The following is a description of a gene set: species: Homo sapiens Genes containing one or more binding sites for (ZNF2) in their promoter regions (TSS -1000,+100 bp) as identified by GTRD version 20.06 ChIP-seq harmonization. from publication Yevshin I, Sharipov R, Kolmykov S, Kondrakhin Y, Kolpakov F (PMID 30445619) Human Gene Set: ZNF2_TARGET_GENES, and this is the list of marker genes: MIR3677HG, BCRP2, ELL, ZSWIM8, ASPHD1, SVOP, FYN, CCDC25, EIF4ENIF1, LIN9, JMJD1C, MRPL22, SLC25A16, ZFAS1, TBL3, PSMD14-DT, MRPL54, SLC24A1, BTG1-DT, PLAAT1, CIB4, MRPL42, TXLNB, CLYBL-AS2, SLC39A11, RBM18, BBS4, SRGAP3, LINC01569 (NCBI Gene Id 100507501), GNB2, PRKCSH, FGD4, RIOX1, HDAC2, METTL1, KCTD14, FAM241B, NSL1, GNA13 (G protein subunit alpha 13), CLPTM1, PHF20, VPS16, FTCD, CCDC88C, ZEB2-AS1, STOX1, CELF4, RPL7A, CNPY2-AS1 (NCBI Gene Id 112268098), DDX19B, RAB11FIP3, TOP3B, DENND5B-AS1, KCTD10, MPLKIP, ZNF385A, TRAPPC3, MYL6B-AS1, CZIB-DT, VPS25, METTL25B, ZSCAN31 (zinc finger and SCAN domain containing 31), TLCD3B, SKIC8, MAPK1IP1L, ITFG2-AS1, BRD8, GRIN2A, CMBL, HSPB6, IL10RA, XPOT, STX16, COMMD2, SERBP1, LTA4H, FNTB, ZCCHC24, UBE2V1P4, ADGRG7, URGCP, ERO1B, AARS1, MMS19, NUCKS1, CUL4A, ZNF3, NTF3, DYRK4, FAM114A2, YBX3, AKAP1, NOL8, RAB2A (RAB2A, member RAS oncogene family), RAC1, CCDC194, B4GAT1-DT, RBM41, LINC03047 (long intergenic non-protein coding RNA 3047), CASP9, AP3B2, TUT1, MRPL48, SERPINI1, ERBIN, POC5, TRAFD1, LRRC23, GUSBP11, HDAC5, RAPGEF3, KLHL17, BUD31, ATP5MC1, BCKDK, NDUFC1, TTLL7 (tubulin tyrosine ligase like 7), ZNF217, LINC01902, HCST, PDS5A, DIAPH1, THUMPD1, SHOC2 (SHOC2 leucine rich repeat scaffold protein), PPP2R5C, ETV2, PARK7, PTPRK, POLR2J3, MED23, INTS8, STARD10, PNPLA3, DHX16, ATAD3A, MYL6, TMEM255A, OGDH, EME1, SH2D7, TIAL1, PRPF40B, UMPS, RPS27, CETN3, UBE2I, PDLIM2, CENPT, SLC25A51, COQ3, MTMR9, STX3, ENSG00000255647, MIR194-1, DECR2, HMG20A, MIR3928, IFFO2, NUFIP2, USP35, CNOT6 (CCR4-NOT transcription complex subunit 6), ST6GAL2, BABAM2, TMEM219, ID2-AS1, BNIP1, SCAI, SYT9-AS1, MIR7977, CRKL, ZNF140, GHR, MRPL4, ISCA1, NSD3, ZNF341, LRRC8C, PRKAR1A, NCOA4, TNPO1, TMTC2, STYK1, EIF1AD, RNU2-17P, ZDHHC17, TMCC2, HSD17B4, SNRPD3, HOXB7, ARHGAP22, MRPL13, NUDC, FRMD4B, KRBA1, MAP3K5, ANP32E, CTPS1 (NCBI Gene Id 1503), LEISA1, KAT6B, AAAS, NCBP2, THG1L (NCBI Gene Id 54974), PBX3-DT, CUL2, H4C8, GGCTP1, ZNF260, STAU2, MIR1273C (NCBI Gene Id 100422821), VAV3, P3H3, RPS3, SHPRH, UBE2D4, ENPP1, ZBTB45, INTS1, WASHC2A, NKAPD1, UBE2Q2P1, BORCS8, RNF146, FCHO2-DT, LRFN2, ZMPSTE24, CHIT1, C10orf88, PRPF18, MPHOSPH9 (NCBI Gene Id 64797), BANF1, LETM2, PRCC, VTA1, ARRDC2, PARN, CASP8, TSC1, PEG10, ZNF790-AS1, DTD1, ZNF511, SNORA13, C1QTNF1, GMNN, DHFRP2, FAAP20, BBX, MCM7, NBPF25P, PGBD2 (NCBI Gene Id 267002), GATA3, PSTK, LINC00240, NUFIP1, FGF13, CPVL, TRUB2, DUSP1, ADAP2, MTRFR (NCBI Gene Id 91574), SUGCT, TSPEAR-AS1, SDCBP2, STK17B, SARAF, CORO1A, FCHO2, ROGDI, GFI1B, CITED2, NUDT3, ERBIN-DT, WDR25, CS, ZZEF1, AKT3, TRIP4, KDM8, FAM133GP, ADAT2, MIF, MIR4799, P2RX5, ZNF30, MIR5091 (NCBI Gene Id 100847023), RNF216, SLC33A1, EFHC1, PROX1 (prospero homeobox 1), ZNF623, MLH1, STUM (stum, mechanosensory transduction mediator homolog), RAP1GAP2, ZNF345, THUMPD3, SLC1A3, NECTIN2, C11orf71, RBM22, TBC1D4, DRG2, COX5A, NUBP1, INO80B, FLNA, CHMP7, BTG1, KCTD5, TMEM161B-DT, CRHR1, HOMER2, ARSA, EMX2, VPS45, HDGFL3, SMARCC2, KLHL32, TSC22D1-AS1, SNORD15A, FNDC5, POP4, RPL5, PPP2R2A, IFT56, CDK16, ADD2, SMG7, RYR2, FAM184A, PANK1, MLEC, CACNA1H, FOXJ1, PEX3, EMC3-AS1, NR2F6, AP4M1, IRF6, NCAPH, DENND4A, FAM227B, SPSB3, SHARPIN, PDZD7, APBA3, GATC, PRELID1, IL12B, IFTAP, SIRT4, JADE2, PDCD6P1, BRF2, MKLN1, KANSL2, TMEM128, SOAT1, EIF2B4, MIR100HG, UBTD1, PFKFB3, ANO8, PDZD2, HUS1, KYAT3, FAM193B-DT, MTBP, ITGA5, TMEM14A, NUDT19, ZNF674-AS1, GPR3, PCDHGB5, SPATS2, CCNJL, RBMX, GORASP2, VPS51, GNB5, KIFBP, LINC02960, PCDH1, CCSER1, ZNF284, SMIM26, KCNJ11, HINT3, LINC02236, ZNF860, EIF1, GNPNAT1, KCNK1, PROX1-AS1, CYB5D2, ENPP3 (ectonucleotide pyrophosphatase/phosphodiesterase 3), ROBO3, KCNIP2, AURKAIP1, GLOD4, KMT2D, CNIH3, PCDHB2, ANKRD24, ZNF225-AS1, DNAI1, MRPL39, ZBTB18, HSPB1P2, RAB24, ZNF674, PDXK, RNA5SP160, UROS, IK, SLC4A1AP, C10orf67, RNU5F-1, NFE2L1-DT, FLJ13224, MYOM3, MAN2A2, ZBTB22, TSPAN9, TSC22D4, DDN, RAB11A, PEX10, SRRM1, SMARCD3, TTLL4, GLA, HOMER1, PRKAA1, SSH1 (NCBI Gene Id 54434), H3-3A, RASD2, WNT1, SPINT2, THAP1, GOLGA3, MGRN1, LINGO1, ST7, MYH9, LASP1, AGAP2-AS1, PKNOX1 (NCBI Gene Id 5316), PMPCB, TXNIP, PAPOLA, SYMPK, TSKU, PCDHB3 (NCBI Gene Id 56132), RNY3, MARCHF6, PHAX, PPP1R9A, NOL12, UBE3B, POGLUT1, CCDC107, AMPH, CSTBP1, FAM107B, PRRG2, ADAM15, PLCXD2, DENND2A, ACP2, ZNF91, AK4, SPG7, CCT2, DUS1L, RBKS, ALG14, DDX55, AP1G1, MFAP3, ZNF827, UNC5B-AS1, PXYLP1, TSC22D1, ANKRD13D, MTRF1, ABCA2, ARHGAP26, IL1RAP, PIK3R2, DOHH, PRTFDC1, APBB2, MAST4, ADRA1A, IKZF5, FLT3LG, LINC03067, SORBS1, DNAH2, TRIP12 (thyroid hormone receptor interactor 12), ARHGAP5 (Rho GTPase activating protein 5), MRPL27, HDAC2-AS2, FBXL18, CDC42BPA, CEP170, ISY1-RAB43, INO80B-WBP1, RPL26L1-AS1, KGD4, ZEB2, COQ10A, TMEM79, SPATA33, SMARCC1, CIMIP5, NR1H3 (nuclear receptor subfamily 1 group H member 3), SRRM2 (NCBI Gene Id 51462), GGA3, ATXN2L, SDHAP4, CIPC, SNAI1, IL4I1, LINC00398, PPP2R3A, CTNNA1-AS1, H1-10, PRMT3, MCRIP2, STX16-NPEPL1, GLCE (NCBI Gene Id 90998), KIFAP3, TPGS1, SCTR-AS1, GINS1, HEXIM1, SKIC2, NUP62, ATRX, DAGLB, LINC01547, TMEM101, LPCAT4, RSPH4A, EMC1, TMEM39B, MAGOH, ZNF30-AS1, KIAA1191, MAP3K21, MED11, TENM3, SMG5 (SMG5 nonsense mediated mRNA decay factor), SIM1, MRPL44, LINC01003, SETD5, TMEM41A, CRBN, SCRN2, CNTNAP2, TNS2, R3HDM2, TRMO, SLC39A3, USP22, EFCAB2, PARL, MYO9B, GUSBP2, MIR4645, PANK1-AS1, ISG20, SUPT7L, REPS1, SRCAP, ELK4, KDM4A-AS1, WIPI2, SPTB, EMC3, ZNF131, C19orf12, VEZT, AMMECR1L, C22orf31, GGTA1, KATNB1, CDK18, INTS12, ABCA3, ADAMTS3, EIF2AK4, SDHAP3, GABBR1, NUDT16-DT, WASHC2C, REEP3, NELL2, CABLES2, RBPMS-AS1, ATF5, EIF4G1, TMEM127, CBX4, RNVU1-23, NFIB, NCBP2AS2, SAMD4A, ODAD2, MARK1, EEF1AKMT3, MMP25 (NCBI Gene Id 82110), PIK3R3, ZMPSTE24-DT, TEDC2, KIF20A, FHIP2B, BRWD1, UBE3D, UCP2, CRELD1, STAG1-DT, TSHZ2, HEY2-AS1, PTK7, RNF157-AS1, ACOX3, CIDECP1, CDH24, RPL29, ZNF714, TRMT44, CHMP1A (charged multivesicular body protein 1A), ZCCHC4, SOCS3, ZKSCAN3, TMEM248, RNU6-1300P, CDKN2AIP, UBTF, RTL8B (retrotransposon Gag like 8B), GPALPP1, ZNF335, MIR3663, NPTX1, DPY19L1, FUBP1, ANKRD52, DOCK7, PPIH, TSKU-AS1, EPB41L4A-AS1, PEAK1, MITD1, CACNA1A, LDHA, MAF1, MRRF, FAM124A, LINC02987, MED26, KCNQ4, KLHL3, SNORD12C, CACUL1, SCCPDH, LRWD1, PSIP1, SNORD24, MAPKAPK5, ITGA3, SNHG30, ANKRD27, HDAC10, FKBP15, KCTD21, CDKN2C, NFKBID, CYB561D1, GLI3, ZNF367, DAZAP2, ERLIN2, MRPL30, RBM28, RBM7, CCZ1P1, LZTR1, GSTCD, MFGE8, BRF1, TATDN3, SLC36A1, FGF7, MVK, SAMD10, IGHMBP2, CCDC144BP, DSP-AS1, ZNF227, RERE, CDC73, TP53BP2, ZNF45, TYW1B, ATXN10, ABL1, RBPMS, SLC9A7, MARCHF7, MTERF4, NBPF12, PHF5AP7, NME2, SLC17A5, ZNF667-AS1, MXI1, CDK19, MET, H3-3A-DT, ADRA2A, DTNB, CLK3, PPP1R26-AS1, NUDT18, TRIAP1, HDGF, MAN2C1, CCDC174 (NCBI Gene Id 51244), ANKRD18B, SEMA6A, PCDHGA6, GINS3 (GINS complex subunit 3), NEBL, KCTD9, DYRK1A, CCN1, COMMD3-BMI1, LINC00680, ST3GAL3, SLC31A1, NPL, RBMXL1, RRAGA, YJU2, RHBDF1, DNPH1, EFNA1, ARV1, KCNQ2, LINC01144, SCYL1 (NCBI Gene Id 57410), FANCC, RIMOC1, XKR6, CLPB, B4GAT1, FGD6, ALKBH3, SEC22B, TAB2, LMTK2, IRF9, GALNT11, MGAT1, IFT57, ZCCHC2, ABCA4 (ATP binding cassette subfamily A member 4), TARS2, SMAD6, DOC2A, HOOK2, C17orf58, SLC6A1, HDAC1, ERMP1, PNP, PHF8, PCED1A, PDE8A, ZNFX1 (NCBI Gene Id 57169), NDUFA2, NRXN2, KCNB1, TSC22D2, SP7, MRPS31, PREP, ZNF667, ENSG00000267260, NCOA7, THAP11, PHF3, BTD, CLUAP1, MAP7D1 (MAP7 domain containing 1), GSTK1, MCRS1, RNF217, NELFE, LETMD1, PDXDC1, COX16 (cytochrome c oxidase assembly factor COX16), PPFIBP2, GATAD2B, LTBP3, POLD1, REXO4, ZMIZ1-AS1, ARHGAP28, IRF1, PAWR, LINC01778, RABEP1, NUDT19-DT, NAV2, AHCYL1, ABT1, CSNK1D, PCID2, MRTO4, ITGAE, ERBB3, VIM, PLEKHG5, LL22NC03-63E9.3, RNU1-6P, RAB26, EPM2AIP1, SNX17, DNAJB12, DPP9 (NCBI Gene Id 91039), ANXA11, TRDMT1, VWA7, BCAR1, MRPL21, PARP6, RBL1, MSC-AS1, RPL15 (NCBI Gene Id 6138), ATP5MC2, STEAP1, INKA1, ST7-OT4, MAGOH-DT, FAM21EP, TXNDC15, GPR199P, RARS1, MFSD4A, ATP6V0A1, WDR47, AP1G2, CLN3, ZNF644, ELOVL1, RNF185, LINC01399, CDCA2, UBAC2, ZNF792, TIPIN, MSC, TASOR2, RNU7-27P, GUCD1, ARRB1, C6orf226, ACBD7, PPAN-P2RY11, GPR89A, SECISBP2L, ADRM1, RPSAP31 (ribosomal protein SA pseudogene 31), KIAA0319, IL15RA, FAM20B, RINT1, FRS2, FAM21FP, GTF2B, SPAG4, SLC30A6, PTCH1, ELOA-AS1, MIR9-2HG, SYNPO2, PDCD2L, RAC3, METTL15, RASGRF2 (Ras protein specific guanine nucleotide releasing factor 2), SCIRT, RPL26L1, STAT6, UBR2, BCCIP, ISG20L2, PSMC4, CALM1, TP53TG5, RPL13P5, PCLAF, SNRPE, FANCD2, LINC02901, THRB-AS1, ALKBH3-AS1, MIR762HG, DTWD1, RPL36, EXTL3, ABCD3, TMEM259, PIH1D2, KIF22, MAP7, RCAN3, PEMT, DMAP1, DLAT, REEP5, PIGG, SGCE, SAP30L, GSE1, ZNF721, PRAME, SMIM7, KCTD19, DDX59 (DEAD-box helicase 59), RNU6-8, ARHGEF7, TEFM, GPATCH3, IRX3, MIR3913-1, GBA1, CCDC177, ALDH1A2, HTT-AS, PTPRZ1, ANP32B, TLE3, TNRC6C, DBNDD2, LIN54, KIAA1586, PRR3P1, HOXD3, MRM3, CDC25C, GTPBP3 (NCBI Gene Id 84705), DOCK7-DT, CZIB (NCBI Gene Id 54987), EIF2D, SYNCRIP, GTPBP10, TRUB1, SELENOH, TEDC1, SCYL3, CENPP, CTNNB1, MRPL1, ZNF212, KPNA3, SERP1, PBX3, NUBP2 (NCBI Gene Id 10101), TCF3, COPZ1 (COPI coat complex subunit zeta 1), COLGALT2, CDK5RAP1, SMIM13, FAM193B, SIRT6, ALDOA, MAGOHB, SMUG1, ACHE, TIPARP, MEF2A, UROD, DYNC2I2, NBL1, CCND1, IPO8, PLEKHG1, ACADSB, BORCS8-MEF2B, SPECC1P1, MIR1302-3, COQ4, PURB, RERG, AMACR, MYG1, PRRC2A, POU6F2, BRD4, CCNC, STAG1, NOSIP, CCDC22, TIPARP-AS1, INTS14, MIR5708, PIK3C3, ESS2, LRRC36, PA2G4, KPNA1, HOOK1, RNF150, BBIP1, SLX9, RPL41, DPP8, TSFM, GPCPD1, ACAT2, MTMR2, CTNNA1, IRAK1BP1, MTO1, YWHAE, ZSCAN26, SYT12, PPP1R3E, METTL26, MCOLN3, SLC44A1, ADGRV1, MAPKAPK5-AS1, ZNF704, PRKCI, TENM3-AS1, ADAMTS19, EXOSC3 (exosome component 3), DEF8, MED22, CDK12, MIR4519, PAFAH2, LSG1, ALG10B, CARNMT1-AS1, GPC6, CSTPP1, RPAP3-DT, PIP5K1B, ANKRD54, FKBP1A, SMARCD2, ISY1, NSG1, RNF43, LRRC59, RPTOR, THRB, UFC1, BOD1L1, LNPEP, RHEBL1, HACL1, TFDP1, C17orf75, MRO, PPP1CC, SMG7-AS1, R3HDM2-DT, TNFRSF10C, TUBA4A, MMAB, GGPS1, PPAN, CCNI, PDK2 (pyruvate dehydrogenase kinase 2), SLC9A1, GPAM, ARNT, SFSWAP, RNF24, DNAJB4, RNPS1, DIXDC1, NUTM2A-AS1, ZC3H6, SLF2, GIPC1, LINC00933, CLASP2, ETV4, ARAP1, MYCL, TBCB, GPR85, TENT2 (terminal nucleotidyltransferase 2), LMAN2, CHD1L, PCDHGB1, PROSER3, GLIPR1L1, PPM1H, FAM200A, DAO, KRTAP5-5 (keratin associated protein 5-5), CD72, CANX, NPAS3, RPL12P14, STX4, MAX, HAUS8, MIR4300HG, TMOD2, DNAJC16, AMD1, BNIP3, RFXANK, POGK, C5orf15, GNAL, ARID4B (AT-rich interaction domain 4B), TACO1, PSMD14, SLC38A2, PFAS, CPLX2, HNRNPH2, TTC13, JARID2-AS1, LRRC37B, NDUFA6-DT, CNOT6L, ABCA17P, NFE2L1, DTX4, RALGDS, NDUFA6, MIR9-1HG, TNS2-AS1, ID2, LINC00662, WDR26, TMEM35B, PDCD10, CACNB3, FNDC3A, ANKRD2, PLEC, HDAC7, LBX1-AS1, FOXJ3, ZFP30 (ZFP30 zinc finger protein), FBXL2, FAM53C, STIP1, KDM1A, MIR7974, GTF3C5, FGF13-AS1, ACBD3, RPL23AP82, BRPF1, SAMD4B, EIPR1, PPCDC, SOCS1, ENSG00000249738, AP3M2, ISLR2, DPYSL3, CDK9, COMMD3, DCAF7, TMEM161B, HOXC5, GRN, GON4L, RNU6-920P, GEMIN5, HS3ST3A1, ENSG00000263011, ENSG00000278356, SLC25A53, SMIM10, ZNF225, SUPT5H, FBXO36, NFE2L2, CAMSAP1, UBB, RPS9, COX7A2, NEURL3, C14orf93, MIR548AW, PDZD9